The following is a description of a gene set: DNA damage can be directly reversed by dealkylation. Three enzymes play a major role in reparative DNA dealkylation: MGMT, ALKBH2 and ALKBH3. MGMT dealkylates O-6-methylguanine in a suicidal reaction that inactivates the enzyme, while ALKBH2 and ALKBH3 dealkylate 1-methyladenine, 3-methyladenine, 3-methylcytosine and 1-ethyladenine. part of: DNA Repair species: Homo sapiens Reactome Pathway: DNA Damage Reversal, and this is the list of marker genes: ASCC3, FTO, ALKBH2, ASCC1, ASCC2, MGMT, ALKBH3, ALKBH5